Given this list of marker genes Irf2bp2, Rnf149, Pxdc1, Mal2, St18, Atad2b, Trim12c, Elfn1, Dsp, Sgcz, Snx31, Vstm2a, Stac2, Akap6, Zbtb43, Casp6, Marf1, Elp2, Cd200, Fhip1a, Camsap1, Prpf39, Nfatc2ip, Spry4, Rab21, Samd1, Ssxb9, Lhfpl6, Abraxas2, Grm3, Cwf19l2, Crppa, Maml3, Kif21a, Or7d10, Mosmo, Srr, Cd27, Fbxl5, here is a description of the gene set: studied in species Mus musculus Mouse Gene Set: MIR_411_5P_MIR_7229_5P from publication Chen Y, Wang X (PMID 31504780) Genes predicted to be targets of miRBase v22 microRNA mmu_miR_411_5p, mmu_miR_7229_5p in miRDB v6.0 with MirTarget v4 prediction scores > 80 (high confidence targets).